Given this list of marker genes ALOX15, GSTA1, ALOX12B, FADS2, ABCD1, ACSL1 (NCBI Gene Id 91249), ALOX12, ELOVL5, ABCD2, FADS1, CYP2J2, ALOX15B, CYP4A22, ELOVL2, ELOVL3, ELOVL1, GSTM2, CYP4A11, PNPLA8, CYP2C18, ALOXE3, GSTP1 (glutathione S-transferase pi 1), here is a description of the gene set: Human Gene Set: GOBP_LINOLEIC_ACID_METABOLIC_PROCESS The chemical reactions and pathways involving linoleic acid, an unsaturated omega-6 fatty acid that has the molecular formula C18H32O2. studied in species Homo sapiens